Given this list of marker genes SERPING1, CFB, CD55, C9, C6, C5, C1S, C2, C3, CFHR1, C4BPA, CLU, CFI, C1QA (complement C1q A chain), CR2, C7, C4BPB, C1R, C8A, CFH, C4B, here is a description of the gene set: Genes in the cancer module 58. Human Gene Set: MODULE_58 studied in species Homo sapiens